Given this list of marker genes Oprl1, Oprd1, Oprk1, Sigmar1, Oprm1, here is a description of the gene set: Mouse Gene Set: GOMF_G_PROTEIN_COUPLED_OPIOID_RECEPTOR_ACTIVITY Combining with an opioid (any narcotic derived from or resembling opium), and transmitting the signal across the membrane by activating an associated G-protein. studied in species Mus musculus